Given this list of marker genes MAP3K20, ADPRH, BCL2L2, ZNF710, DERA, PDPR, ZNF689, PBX1, WTAP, CNPY3, ALDH8A1, TSTD2, CDK13, DENND4C, ADCY1, CDKN2AIP, SESN3 (sestrin 3), DAZAP2, ADCYAP1, DPYSL5, CX3CR1, CACNB3, USP3, SCAP, UNG, SAMD12, RAP1GAP2, MAP1LC3B, ULK2, ABCF1, ESYT2, NFIC, CENPO, MED29, SHISA2, PLPBP, MTDH, KCNMB4, TSHZ3, XRN1, SOX11, DSTN, UNC5A, ZCCHC10 (NCBI Gene Id 54819), KRTAP20-3 (NCBI Gene Id 337985), GJC1, TRAK2, MAN1A1, NUP93, ABCG4, CCDC68, RTN4RL1, APPL2, SRGAP2C, NT5DC3, BRD1, ATP1A2, PSME1, EXPH5, AIPL1, STK35, NEUROG1, IGSF21, LUC7L3, ST6GALNAC6, RAB43, B3GAT3, ZSWIM6, MEF2A, TTC39C, MED13L, here is a description of the gene set: Human Gene Set: MIR550A_3_5P_MIR550A_5P studied in species Homo sapiens Genes predicted to be targets of miRBase v22 microRNA hsa-miR-550a-3-5p, hsa-miR-550a-5p in miRDB v6.0 with MirTarget v4 prediction scores > 80 (high confidence targets). from publication Chen Y, Wang X (PMID 31504780)